The following is a description of a gene set: Kit receptor signaling species: Homo sapiens Human Gene Set: WP_KIT_RECEPTOR_SIGNALING, and this is the list of marker genes: KITLG, KIT, INPP5D, PLCG1, SOCS6, GRB10, STAT5A, CBL, SHC1, MAPK14, PIK3R1, RPS6KA3, MAPT, DOK1, BCL2, PIK3R2, RAF1, LYN, HRAS, MAPK3, SNAI1 (NCBI Gene Id 6615), SNAI2, RPS6KA1, MAPK8, CRK, FOS, AKT1, SRC, STAT1, TEC, MATK, STAT3, FYN, EP300 (E1A binding protein p300), JAK2, BAD, TBX2, JUNB, MITF, RPS6KB1, PTPN6, SH2B2, PTPN11, VAV1, MAP2K2, PRKCB, FOXO3, MAP2K1, STAT5B, GAB2, MAPK1, PRKCA, RPS6, GRB2, CRKL, BTK, SOCS1, GRB7, SOS1